Given this list of marker genes FYN, CCR2, SHANK3, FRRS1L, IFNGR2, CCL2, NECAB2, IFNG, NLGN3, CX3CL1, EPHB2, PRNP, here is a description of the gene set: studied in species Homo sapiens Human Gene Set: GOBP_REGULATION_OF_GLUTAMATE_RECEPTOR_SIGNALING_PATHWAY Any process that modulates the frequency, rate or extent of glutamate receptor signaling pathway.